Given this list of marker genes Smyd3, Prmt1, Setd3, Kmt5b, Mecom, Prdm6, Ezh1, Prmt5, Inmt, Prmt2, Kmt2b, Fbl, Pemt, Setbp1, Nnmt, Mettl15, Kmt2a, Setd1a, Tfb1m, Eef1akmt1, Trmt1, Jarid2, Prmt8, Ezh2, Eef2kmt, Suv39h2, Zcchc4 (NCBI Gene Id 78796), Tfb2m, Setd2, Mettl21c, Prdm8, Eef1akmt3, Nsd2, Atpsckmt, Etfbkmt, Mettl18, Mettl23, Smyd1, Prdm9, Smyd5, Hnmt, Suv39h1, Vcpkmt, Prmt3, Setd7, Hemk1, Kmt5a, Kmt2d (NCBI Gene Id 381022), Setdb1, Rnmt, Ndufaf7, Ehmt2, Dimt1, Trmt11, Setmar, Gnmt, Kmt2c, Nsd3, Kmt2e, Mettl5, Kmt5c, Setd6, Carm1, Setd4, Dot1l, Thumpd3, Mettl13, Wdr5, Prmt9, Antkmt, Smyd2, Prdm16, Ash1l, Nsd1, Ehmt1, Ash2l, Fdxacb1, Pnmt, Prmt7, Prmt6, Fbll1, Camkmt, N6amt1, Setd1b, Mettl9, Mettl21a, Setdb2, Eef1akmt4, Eef1akmt2, Fbxo11, Setd5, here is a description of the gene set: species: Mus musculus Mouse Gene Set: GOMF_N_METHYLTRANSFERASE_ACTIVITY Catalysis of the transfer of a methyl group to the nitrogen atom of an acceptor molecule.